Given this list of marker genes CASP9, CASP7, CYCS, CASP3, APAF1, XIAP, here is a description of the gene set: Procaspase-3 and 7 are cleaved by the apoptosome. part of: Cytochrome c-mediated apoptotic response Reactome Pathway: Activation of caspases through apoptosome-mediated cleavage species: Homo sapiens